Given this list of marker genes Wnt1, Gsx2, Pax7, Lbx1, Gsx1, Tal1, Ascl1, Lhx5, Lhx1, Wnt3a, Lmo4, Pax3, Lhx3, Gdf7, here is a description of the gene set: Mouse Gene Set: GOBP_SPINAL_CORD_ASSOCIATION_NEURON_DIFFERENTIATION species: Mus musculus The process in which neuroepithelial cells in the neural tube acquire specialized structural and/or functional features of association neurons. Association neurons are cells located in the dorsal portion of the spinal cord that integrate sensory input. Differentiation includes the processes involved in commitment of a cell to a specific fate.